The following is a description of a gene set: species: Homo sapiens Any apoptotic process in a fibroblast, a connective tissue cell which secretes an extracellular matrix rich in collagen and other macromolecules. Human Gene Set: GOBP_FIBROBLAST_APOPTOTIC_PROCESS, and this is the list of marker genes: NUPR1, API5, GAS6, PIK3CA, BCL2L11, STK17B, STK17A, BAK1, BID, BTG1, TP63, IER3IP1, BBC3, CASP3, XRCC2, CHD8, CASP7, PIK3CG, MIR181B1 (microRNA 181b-1), MYC, CASP9, PRDM11, MIR24-1, SFRP1, CFDP1, TP53, CUL3